Given this list of marker genes TGM2, EHMT2, SLC1A3, CCNA2, CRH, COMT, SLC1A1, PPP1R1B, CRHBP, SLC1A2, here is a description of the gene set: species: Homo sapiens Any process that results in a change in state or activity of a cell (in terms of movement, secretion, enzyme production, gene expression, etc.) as a result of a cocaine stimulus. Cocaine is a crystalline alkaloid obtained from the leaves of the coca plant. Human Gene Set: GOBP_CELLULAR_RESPONSE_TO_COCAINE